The following is a description of a gene set: species: Homo sapiens Reactome Pathway: Signaling by ALK fusions and activated point mutants ALK is activated in a range of cancers as a result of amplification or overexpression, fusion event or activating point mutations, resulting, in general, in constitutive activation of intracellular signaling. The major pathways initiated downstream of activated ALK are STAT3 and, to a lesser extent, STAT5 signaling and signaling through the MAP kinase, PI3K/AKT and PLC gamma cascades. part of: Signaling by ALK in cancer, and this is the list of marker genes: UBB, ALK, IL10RA, HDAC1, UBC, TWIST1, AGO1, ICOS, ATIC, NOTCH1, IL10, CDKN1A, GRB2, PIK3R1, SHC1, PLCG1, AGO3, BCL11A, TPM4, TP53, RNF213, STAT1, FOXM1, MAPK9, MDM2, IRS1, EML4, PRKAR1A (protein kinase cAMP-dependent type I regulatory subunit alpha), SKP1, PTPN6, MOV10 (Mov10 RNA helicase), MAPK8, DNMT1, HIP1, FRS3, MECP2, TYK2, PIK3CB, RANBP2, STAT3, RB1, WDCP, MCL1, AGO4, RRBP1, STAT5A, NPM1, GCC2, CCNB1, PPFIBP1, CLTC, DCTN1, GZMB, ZAP70, CEBPB, KLC1, TNRC6C, SQSTM1, PIK3R2, MSN, KIF5B, TPR, CUL1, BCL2A1, BIRC6, TPM3, PRF1, RPS6, IRF4, STRN, MIR21, PPM1B, RBX1, JUNB, TFG, EIF2AK3, SEC31A, MYH9, ZC3HC1, PIK3CA (NCBI Gene Id 5290), RPS27A, MAPK1, EEF1G, CARS1, AGO2, LMO7, FRS2, MAPK3, VCL, UBA52, FN1, JUN, IL22